The following is a description of a gene set: studied in species Mus musculus Mouse Gene Set: REACTOME_INFLAMMASOMES Inflammasomes, and this is the list of marker genes: Nlrp1a, Mefv, Panx1, Sugt1, Txnip, Hsp90ab1, Bcl2, P2rx7, Nlrp3, Pycard, Pstpip1, Aim2, Bcl2l1, Txn1